The following is a description of a gene set: Any process that stops or reduces the activity of a transporter. species: Homo sapiens Human Gene Set: GOBP_NEGATIVE_REGULATION_OF_TRANSPORTER_ACTIVITY, and this is the list of marker genes: KCNQ1, CTTNBP2NL, UBQLN1, OSR1, GPR35, SLN, GRP, NDFIP2, NDFIP1, WWP2, MMP9, GOPC, SUMO1, CALM1, STK39, CBARP (CACN subunit beta associated regulatory protein), CACNA1F, FMR1, TCAF2, KCNE3, KCNE1, KCNE2, CRHR1, KCNRG, ANK3, GNB5, CALM3 (calmodulin 3), PLN, TLR9, KCNAB1, PPIF, CALM2